Given this list of marker genes JAK1, INPP4A, SON, PPP4R3B, SMIM7, NPHS2, ST8SIA4, ADM, ARMCX3, AK1, PGGT1B, RALB, CXCL2, PDE10A, HS3ST6 (heparan sulfate-glucosamine 3-sulfotransferase 6), HSP90AA1, NEDD9, RCAN1, MKRN1, RGS2, PRKCA, ITGA8, QKI, ITPRID2, GIMAP4, ASB15, NHERF2, LMO2, CAVIN1, PAG1, FAM241A, RCAN2, EP300, ARHGEF15, MYOF, LMO7, DNAJB4, COL4A4, JAM2, CDYL, HEATR5B, GJA3, TP53INP1, NFKBIA, FAM135A, PURB, SEMA3B (NCBI Gene Id 7869), CBFA2T3, TOR1AIP2, MARK1, USP46, CHMP1B, KMT2C, ARHGAP31, DENND6A, MEF2C, TMEM26, SGK1 (serum/glucocorticoid regulated kinase 1), LIN54, ABCB1, BTNL9, NEAT1, TMTC1, SLC12A6, ATP8B1, MSRB3, RBPMS, ZBTB38, CFLAR, SPTLC2, UGP2, ADGRF5, SGIP1, NT5E, SGMS1, CDC42EP3 (NCBI Gene Id 10602), C1GALT1C1, DUSP6, HLA-B, SLCO2A1, SERINC3, GLRX2, TMED5, PCMTD1, CLIP1, KITLG, MAST4, AGTR1, PPP1R13B, DTNA, TRPC1, MCF2, KRT7, RPS6KA5 (ribosomal protein S6 kinase A5), KNG1, TSPAN12, NSF, CPEB2, ADGRA2, MMP23B, NEBL, DSP, SEMA3E, ANXA4, ATP10A, PTPN12, PHF20, KANK3, CYYR1, TNS2, CTBS, IQGAP2, PIK3CA, CD38, STK3, LPIN2, DYNC1LI2, TTLL7 (NCBI Gene Id 79739), SETD7, SPRED2, SH2D4A, FLI1, FAM13C, ACKR3, TPM1, TNFAIP3, ADCY1, MED23, PARP14, EIF2S3, MBD5, TRIM5, LYSMD3, ZBTB8A, IL6ST, TOP1MT, THBD, CYP4B1, TADA2B, AMY2B, ARL13B (ADP ribosylation factor like GTPase 13B), USP12, COQ10B, JARID2, ST3GAL6, HIVEP2, USP33, SLC38A9, SH3BP5, RAPGEF5, INF2, WSB2, NADK2, GYG1, FERMT2, SHROOM2, ARHGAP28, KIRREL1, CPEB4, ARNT, CCN2, GOLGA3, SRGN, MME, CABLES1, CYRIA, EXOC8, C11orf52 (NCBI Gene Id 91894), SPOP, LPAR4, ZFYVE16, ZBTB7C, GATA3, MTSS1, ZNF185, PFKFB3, TMEM9B, B3GNT2, WDFY1, TMEM64, DCAF5, YOD1, TDRP, SPIRE1, RNF103, EAF1, H1-2, VGLL3, RDH16, RIOK3 (NCBI Gene Id 8780), ADAM9, DBT, FGD4 (FYVE, RhoGEF and PH domain containing 4), NCOR1, ITGB8, TMC7, SLC48A1, SOX7, ZNF729, DMXL1, OPTN, PDP1, LGALSL, LIMS1, IL2RG, MYZAP, FMNL2, EFNB1, RAP1A, SYNJ2BP, PLEKHG1, GRK5, CBL, NBEAL1, CDH5, DOCK5, MALT1, GSN, PANK3, RIPOR2, SLC33A1, RASA2, GUCY1A1, RREB1, MPP3, CD59, EMC7, TNFRSF11B, PTPRB, ARHGEF16, TGFBR3, EHD4, VCL (vinculin), PDE4DIP, ATP2A3, PRX, FRMD6, ITGA9, HSPA12A, PPP1R16B, NSMAF, CLEC14A, ARHGAP29, DENND2B, RAB3GAP2, MYO1D, RASSF10, STAG2, ERG, AFAP1L2, CLOCK, DAAM2, RMDN1, ZFR, RIN2, TCEANC2, H2AC25, KIF1B, MPRIP, BTAF1, UBE2V2, EDEM3, P3H2, ACER2, PSD3, TLE4, CCDC126, MMRN2, CALM2, RNF13, DNAJB14, CFAP68 (NCBI Gene Id 737), HLX, MCL1, CALCRL, SGPP1, EXOC3L2, DYNLT3, FNDC3B, SH3GLB1, IDS, PARVA (NCBI Gene Id 80050), KRIT1, FOXN2, SNCAIP, FRS2, ELL2, CLIC5, PLAT, KANK4, HS3ST3B1, MYO10, TM4SF1, PCOLCE, SHISA3, RFK, ESCO1, FAM174A, LZTFL1, PCMTD2, FRYL, PTGER4, VAMP5, MBNL3 (NCBI Gene Id 55796), PLSCR4, LYPLA1, B3GALT2, PLPP1, LASP1, TIPARP, NFIL3, DUBR, SP2, MAFB, ACSL4, CXCR4, TRAK2, MINDY2, STXBP3, CD47, THBS1, ZNRF2, TRIB2, GINM1, TMEM150C, TENT5A, TMEM33, CBLB, HTRA1, PPIP5K2, SCOC, KDM4C, OSBPL5, PITPNC1, HHEX, TSPAN5, THSD7A, CYP20A1, YES1, FABP4, PUM2, VANGL1, FNDC3A, SHE, ST6GALNAC3, TAOK1, SH3BGRL2, SLC12A1, PELI2, UBR3, CTSS, SNAPC3, BMPR1A, DOCK4, CITED2, EMCN, MYCT1, TRIP11, TECPR1, GPC1, SLC38A4, ARMCX1, ICAM2, TMEM30A, KIF5B, ACAP2, FRK, ARRDC3, KDM7A, USP42, YPEL5, CSGALNACT2, TUT7, WWC2 (NCBI Gene Id 80014), BBX, CTTNBP2, KLF3, CRIM1, ITSN1, RRAS2, TBC1D1, BMI1, HSPA1B, ITGA4, ARHGAP24, PRKCH, GEM, PLPP3, KBTBD11, GAB2, TEK, TASOR, SAMD8, C18orf54, BACE1, CRYAB, NOCT (NCBI Gene Id 25819), PGM2, ARHGAP5, SCHIP1, RAB6B, CAMK2D, RNF11, TPP1, PLCL1, EHD3, LYST, PRKAA1, PTPRO, APBB2, INO80D, ZHX1, TLR3, CHPT1, ENDOD1, SH2B3, EML1, RBBP6, RIPOR1, LDB2 (LIM domain binding 2), LMBRD1, TANC1, SYT17, EBF1, ARHGAP17 (NCBI Gene Id 55114), IGIP, ABI3, RAPGEF2, ETS1, TMEM65, CHAC2, ATG4A, GPR146, ARID4A, AKIRIN1, PDLIM2, CDC73, MTMR6 (NCBI Gene Id 9107), KLHL5, PCDH12, NXT2, GMDS, VSIG10, OSMR, CDC42BPG, PTPRJ, RBMS1, ITGB5, PURA, GGCT, LRCH1, NCK2, DCDC2, SERINC5, STAT1, ARVCF, STARD8, IRF2BP2, ATXN7L1, ING3, ADGRL3, AMOTL1, SEMA3G, E2F5, UBE2Q2, AGFG1, SNX13, AP5M1, NPL, LPP, VSTM4, DSTYK, COL12A1, NOSTRIN, SLC36A4, IFI16, IKZF5, SLK, ARHGAP26, ABCA5, ACOX1, RO60, LNPEP, PDGFB, PREX2, CEMIP2, MED13, FOXC2, UMOD, GALNT10, HYCC2, ITSN2, SLAIN2, TCF25, JCAD, DIAPH2, EGF, THAP2, SLC12A2, TEX2, IL10RB, COL4A5, PON2, FYN, ART3, KANK1, IRGM, GARRE1, SNAP23, PLSCR1, NOTCH4, GIMAP6, FAM174B, CEP85L, TMEM204, ITGA2, H3C15, TSPAN8, SNRK, CLCA3P, CAVIN2, HSDL2, GALC, RIMOC1, ASH1L, PALM2AKAP2, SOX17, ARID5B, IFRD1, WWTR1, SYNPO, EPHB1, VIM, ENTPD7, NES, CORO1A, FAM76A, HOMER1, NLK, PARD3B, ZDHHC14, ABLIM3 (actin binding LIM protein family member 3), MAP3K2, MED12L, CYRIB, SLITRK6, PCDH17, NPR3, ARHGEF18, FBXO3, GABRA4, CLEC4A (C-type lectin domain family 4 member A), DIPK2A (NCBI Gene Id 205428), EDNRB, RORA, TBX3, SNTB1, FAM120A, TMEM106B, MCC, CD36 (CD36 molecule (CD36 blood group)), LDAH, CDKN1C, EFNB2, ZEB2, SEC11C, ADGRE5, C16orf87, CELF2, PLOD2, LRRFIP1, LATS2, ROCK1, CERS6, HEY2, SECISBP2L, RC3H2, AGO4, YIPF4, DGKH, MYO1B, CAST, SULF2, MERTK, MAP3K20, UACA, ZFX, RNF6, NCOA4, ARFGEF3, CPNE8, MAGI2, SIRPA, APP, GRM7 (NCBI Gene Id 2917), RASSF9, MTM1, TCF21, RAPGEF3, JADE1, GLCCI1, WASHC4, CCPG1, MGAT5, SACM1L, TCP11L2, MTUS1, GADD45A, C6orf120, TCIM, LOXL2, RASL11A, USP25, SPEG, PTPRC, ANXA1, RILPL1, FAM43A, ITGB1, CARD10, HAGH, MAN1A1, PARP4, MOSPD2, MBLAC2, DUSP3, PDE2A, H6PD, MYOM2, PRR15, LRRC28 (leucine rich repeat containing 28), SERPINI1, CDC14A, MIR22HG, PPP1R2, TENM2, SLC2A3, ADAMTS16, HSPA1A, RTN4RL1, CCNB1IP1, PALLD (NCBI Gene Id 51653), LRMDA, GIMAP1, STRN, CLEC1A, MYADM, PPM1K, ERGIC2, DST, AIF1L, ZNF518A, TBC1D12, DKK2, CREBZF, VPS13A, HEATR5A, ATP7A, DPP4, ACBD5, ARAF, MYO1C, H3C13, NTN4, SLC27A3, ZBTB46, AVPR1A, GNB1, VEGFA, SSBP2, RERG, GPD2, TNFAIP8, TUBB2A, LIFR, LRBA (LPS responsive beige-like anchor protein), MICU1 (mitochondrial calcium uptake 1), SELENOT, MACF1, MYO18A, FOXC1, PROS1, CAV2, FRY, FUT11, ARL8B, OTUD7B, HIPK3, PTPRVP, SFMBT1, PBX2, MTCL1, MTMR2, ULK2, TIMP3, KLK1, VMA21, SLC2A12, RANBP9, KCNK6, PTPRG, TGFBR2, PRKG1, RNFT1, UBLCP1, ILDR2, RAP1B, H2BC4, PDE4B (phosphodiesterase 4B), SLFN5, TMBIM1, ZNF484, DNAJB6, EPAS1, SAMD4A, CCRL2, ENPP4, C1QTNF7, DACH1, C8orf58, VPS54 (NCBI Gene Id 51542), MYO1E, TOB1, CREBBP, EBAG9, HIP1, USP9X, POLB, CTDSPL, NRROS, DEGS1, LEMD3, CDKL2, RABGAP1L, NID1, RNPC3, MBNL2, KLF4 (KLF transcription factor 4), RASGRP3, FLT1, SLC35A5, TLR4, CALM1, PLCE1, OSBPL8, PLD1, ZBTB4, IL13RA1, ADAMTS5, LMX1B, TMCC2, CSNK1G3, PRDM1, TTC14, GPRIN3, FOXP2, DPYSL2, PTAR1, COL4A3, SEMA5A, SGK3, MAP3K3, BTBD3, NID2, TRIM23, HOPX, NECTIN3, ZBTB44, CRK, LUC7L2, ADGRE4P, RETREG1, MMD, GTF2A1, ANKRD29, SOWAHC, MAPT, ARAP2, SDC2, ATG10, ZNF319, TACC1, HIVEP1, CEBPB, SHROOM3, SORBS1, ADGRL4, KDM6A, P2RX4, CSGALNACT1, PER2, AP4E1, PLXDC2, ARHGEF26, LYZ, ITPKB, MYO6, SERINC1, RAPGEF4, PARD6B, ELF1, BICD2 (BICD cargo adaptor 2), WIPF3, IFI35, SCN7A, PALS1, SCD, RICTOR, IQSEC1, RHPN1, PHF20L1, SOS2, METRNL, COLEC12, GOPC (NCBI Gene Id 57120), AHNAK (AHNAK nucleoprotein), VASN, SLC17A5, TXNIP, TMCC3, FGD5, ATXN7, MGLL, GVINP1, ANKRD33B, ARMC8, CD55, H3-3B, GIMAP8, ARRB1, VPS37A, SERPINB6, CCDC82, EEIG1 (estrogen-induced osteoclastogenesis regulator 1), COL25A1, GULP1, LIPA, PARP12, ECPAS, DDN, ZC3HAV1, TSPAN2, DENND11, EPN2, IRS1, CYBB, PHLPP1, HECW2, NATD1, TMOD3, here is a description of the gene set: Mouse mutations have provided tremendous insights into the molecular basis of renal and glomerular development. However, genes often play important roles during multiple stages of nephrogenesis, making it difficult to determine the role of a gene in a specific cell lineage such as the podocyte. Conditional gene targeting and chimeric analysis are two possible approaches to dissect the function of genes in specific cell populations. However, these are labor-intensive and costly and require the generation, validation, and analysis of additional transgenic lines. For overcoming these shortcomings and, specifically, for studying the role of gene function in developing glomeruli, a technique to isolate and purify glomeruli from murine embryos was developed. Combined with gene expression profiling, this method was used to identify differentially expressed genes in glomeruli from Pod1 knockout (KO) mice that die in the perinatal period with multiple renal defects. Glomeruli from early developing stages (late S-shape/early capillary loop) onward can be isolated successfully from wild-type and KO kidneys at 18.5 d postcoitus, and RNA can readily be obtained and used for genome-wide microarray analysis. With this approach, genes that are differently expressed between glomeruli from Pod1 KO and wild-type mice were identified, including a four-fold reduction of alpha 8 integrin mRNA in glomeruli from Pod1 KO mice that was confirmed by immunostaining. This procedure may be adapted to any transgenic strain, providing a rapid and efficient method to dissect the function of specific genes in glomerular development. species: Mus musculus All significantly down-regulated genes in kidney glomeruli isolated from TCF21 knockout mice. from publication Cui S, Li C, Ema M, Weinstein J, Quaggin SE (PMID 16207825) Human Gene Set: CUI_TCF21_TARGETS_2_DN